The following is a description of a gene set: The aggregation, arrangement and bonding together of a set of components to form a manchette. species: Mus musculus Mouse Gene Set: GOBP_MANCHETTE_ASSEMBLY, and this is the list of marker genes: Ift56, Ccdc146, Pfn4, Axdnd1, Meig1, Stk33, Spag17, Cfap70, Hook1, Cfap53, Cep131